Given this list of marker genes EIF4EBP2, CNOT1, DHX36, WTIP, BTG2, LARP1, TYMS, RACK1, MIR148B, MIR98, PURA, XRN1, IGF2BP3, CELF4, MIR210, PURB, MIR218-1, ZNF540, CIRBP, MIR200B, PML, LIMD1, EIF2AK1, MIRLET7A1 (NCBI Gene Id 406881), RPL13A, MIR27A, AGO4, MRPL13, SYNCRIP, UNK, MIR28, AJUBA, MIR379, WFS1, EPHA4, IGF2BP1, MIR133B, MIR128-1, FMR1, MIR16-1, PAIP2, MIR590, EIF3E, ZAR1, MIR6086, MIR208A, SHFL, EIF2S1, MIR24-1, DDX6, IFRD2, MIR520B, MIR29C, MIR520E, EPRS1, MIR145, EIF2AK2, MIR495, MIR106A, MIR9-1 (microRNA 9-1), NMNAT2, CELF1, MIR107, EIF4E2, SAMD4A, BANK1, CPEB1, RBM4, MIR135B, ALKBH3, MIR29B1, SRP9, MIR221, AGO3, MIR21, MIR10B, MIR346, RNF139, MIR19B1, LSM14A, DNAJC3, MIR298, MIR345, MIR106B, MIR182, MIR103A1, MIR659, MIR141, EIF2AK3, SHMT1, EIF4G1, MIR15B, MIR204, CPEB3, GIGYF2, TPR, MIR132, MIR200C, TNRC6A, RGS2 (NCBI Gene Id 5997), HABP4, YBX1, TIA1, DAPL1, ATF4, PARP16, GAPDH, EIF6, WT1, OTUD6B (NCBI Gene Id 51633), EIF4EBP1, MIR939, MALSU1, C8orf88, DAP, ILF3, MIR1271, TNRC6B, MIR146A, PRKCH, MIR29A, NANOS1, MIR520C, GZMB (granzyme B), SCRIB, MIR874, CSNK2A1, MIR499A, INPP5E, SESN2, MIR26B, MIR448, MIR214, DDX3X, PUS7, MIR134, MIR148A, MIR503, IGF2BP2, SERBP1, TRIM71, MIR31, MIR877, NANOS2, PCIF1 (phosphorylated CTD interacting factor 1), DAPK1, RPS3, IGFBP5, NCL, DHFR, MIR181C, PATL2, AGO1, RIDA, MIR125A, MIR212, MIR20A (NCBI Gene Id 406982, microRNA 20a), MIR365A, MIR181A2, FXR1, MIR15A, EIF4ENIF1, CAPRIN1, IREB2, MIR125B1, TOB1, MIR96, ACO1, MIR378A, RBM24, MIR100, ANG, EIF4E, CALR, MIR299, EIF2AK4, AGO2, EIF4A3, MIR483, DHFRP1, MIR126, CNOT9, EIF4EBP3, MIRLET7I, MIR27B, NANOS3, DAPK3, QKI, ZNF598, PAIP2B (NCBI Gene Id 57218), CPEB2, HHEX, LIN28A, SAMD4B, MIR17, PRG3, ZAR1L, MAP3K20, MIR1-1, ENC1, MIR144, CNOT10, MIR181D, MIR138-1, TNRC6C, ZFP36, CAPRIN2, MIR92A1, MIR181B1, PRKCA, CYFIP1, MIR205, GRB7, RARA, CPEB4, MIR101-1, here is a description of the gene set: Human Gene Set: GOBP_NEGATIVE_REGULATION_OF_TRANSLATION species: Homo sapiens Any process that stops, prevents, or reduces the frequency, rate or extent of the chemical reactions and pathways resulting in the formation of proteins by the translation of mRNA or circRNA.